The following is a description of a gene set: Mouse Gene Set: chr12D3 species: Mus musculus, and this is the list of marker genes: Gm23195, 1700105G05Rik (NCBI Gene Id 73550), Gm40548, Gm40538, Gm7119, Gm6841, Rpl31-ps1, Tshr, Gm18968, Sel1l, Gm18504, Gm4808 (NCBI Gene Id 217786), Gm23249, Gm16876 (predicted gene, 16876), Gm18388, Mir8099-2, 5430427M07Rik, Gm26512, Gm47742, Gtf2a1 (general transcription factor II A, 1), n-R5s65, Gm21614, 4930559C10Rik, Gm19540, Gm25776, Gm2139, Dio2, 4930544I03Rik, Nrxn3, Gm18749, Gm18500, Gm21007, Gm18827, Gm9726, Gm21051, Ston2, Gm18621, Cep128, Gm40598